The following is a description of a gene set: studied in species Homo sapiens Human Gene Set: MOOTHA_MITOCHONDRIA DNA microarrays can be used to identify gene expression changes characteristic of human disease. This is challenging, however, when relevant differences are subtle at the level of individual genes. We introduce an analytical strategy, Gene Set Enrichment Analysis, designed to detect modest but coordinate changes in the expression of groups of functionally related genes. Using this approach, we identify a set of genes involved in oxidative phosphorylation whose expression is coordinately decreased in human diabetic muscle. Expression of these genes is high at sites of insulin-mediated glucose disposal, activated by PGC-1alpha and correlated with total-body aerobic capacity. Our results associate this gene set with clinically important variation in human metabolism and illustrate the value of pathway relationships in the analysis of genomic profiling experiments. from publication Mootha VK, Lindgren CM, Eriksson KF, Subramanian A, Sihag S, Lehar J, Puigserver P, Carlsson E, Ridderstråle M, Laurila E, Houstis N, Daly MJ, Patterson N, Mesirov JP, Golub TR, Tamayo P, Spiegelman B, Lander ES, Hirschhorn JN, Altshuler D, Groop LC (PMID 12808457) Mitochondrial genes, and this is the list of marker genes: CLPX, UCP2, PDK1, COX6B1, ATPAF2, NPIPA1, MTIF2, TFB2M, MCAT, NDUFS6, R3HCC1L, STAR, IDH3B, NDUFS4, CROT, SLC25A31, LYPLA2, VDAC3, BEX3 (brain expressed X-linked 3), NDUFB8, SLC30A9, BIK, MRPL16 (mitochondrial ribosomal protein L16), MRPS18C, DLAT, TIMM22, GNAS, SLC25A15, HADHA, BID, DMAC2L, BCAT2, NME2, SLC25A20 (NCBI Gene Id 788), DGUOK, MRPL22, FXN, ANXA7, FAM3A, TXN2, AMACR, NDUFB2 (NCBI Gene Id 4708), HSPE1, TIMM17A, COX17, STARD3, PPOX, TOMM22, COX5A, SSBP1, SMCP, GPX4, PTPRA, SLC25A40, NDUFA6, POLR1B, ACP6, FIBP, ATP5MC2, TIMM44, CA5A, MRPL11 (NCBI Gene Id 65003), COX4I1, GFM1, CPS1, FHP2, DIABLO, POLRMT, SLC1A3, FDXR, MAP3K1, MRPS7, HADH, NDUFS1, CYP27A1, RPAIN, EHHADH, ATP5MG, COX6A1, ADCK2, SLC9A6, SHB, TBCB, PKLR, LGALS3, WARS2, ALDH2, ETFA, MTO1, BCL2A1, PCCA, YARS2, RAF1, AK4, FECH, MRPL19, TOMM40 (translocase of outer mitochondrial membrane 40), BDH1, PLA2G1B, CYP2E1, MPO, SHMT2, LCAT, CYB5A, ETFDH, HTRA2, MRPS14 (NCBI Gene Id 64961), MYCBP, AFG3L2, NDUFS5 (NADH:ubiquinone oxidoreductase subunit S5), ATP5PD, POR, MRPS18B, NDUFB4, ABCB7, PCK2, NDUFAB1, TPO, MRPL28, UQCRH, CASQ1 (NCBI Gene Id 844), TIMM8B, SLC25A28, MRPS11, ATP5F1E, PDHB, MMUT, ENDOG, CFAP410, BNIP3L, ACAA1, NDUFS2, HSPA9, SARDH, METTL17, TYMP, SPG7, HAX1, ME3, MRPS27, PPA1, MRPS22, POLG, CASP2, MRPL12 (mitochondrial ribosomal protein L12), COX10, SLC25A4, TOMM34, PRPF6, CYP11B1, NFS1, PDK3, COX7C, GATM, NDUFA10, SDHB, HADHB, SDHC, SLC25A10, MRPL18, SLC25A21 (solute carrier family 25 member 21), NDUFC1, SUCLG1, YME1L1, NDUFA7, SDHA, PSEN2, NDUFB1, CYB5R3, IMP3, COX7A2, ZNF33B, OTC, COX7B, CRY1, ACADVL, AMT, ACADL, PDK4, HMGCS2, TFB1M, SLC25A17, FDX1, ECHS1, UQCR11, TK2, UQCRFS1, PRKCD, MLYCD, UQCRB, MRPL46, ACAD8, NDUFC2, PYCR1, SLC25A32, G6PD, FARSA, COQ7, GAS8-AS1, CASP8, ATP5MF, ME2, NDUFB5, MRPL24, TWNK, EMC8, SLC25A12, MRPL42, NME4, MRPL9, PLA2G2A, ATP5IF1, DDX28, VAV1, APAF1, MRPL57, MTHFD2, MRPS15, SLC25A36, LONP1, NNT, SDHD (NCBI Gene Id 91899), TNFSF10, NDUFB6, PYGB, MTHFD1, SOD2, NDUFA3, BAK1, NCAPH2, ACADS, GLS2, APP, MBD3, GCK, MTRF1, PRDX3, SLC25A22, ACO2, ECI1, DUT, C1QBP, PC, TSFM, FH, NDUFB7, CPOX, CPT1B, SLC25A13, BCL2, CBARP (CACN subunit beta associated regulatory protein), LARS2 (leucyl-tRNA synthetase 2, mitochondrial), ERBB2, CKMT2, SLC25A38, UQCRC1, NPIPB3, UCP1, ABAT, ACADSB, CYBB, CLN3, POLR3B, DNASE2, POLG2, AK2, DHODH, MRPS12, BCS1L, TIMM8A, ATP5PF, CAD, DBT, OAZ3, MRPS31, H2BK1, SURF1, MRPL20, LMF2, COX6C, CS, MRPS28, TIMM10B, ABCF2, ETFB, MRPS35, PDHX, FARS2, TFAM, ATP5MJ, CYC1, CYP27B1, MRPL44, ACAA2, HSPD1, ATP5PB, CDC37P1, ECI2, GPD2, NDUFA5, BCKDK, COX6A2, SLC1A2, SLC25A5, CKMT1B, ALAS1, CYP11B2, BCKDHA, SLF2, NDUFA1, MRPS18A, MRPL13, DAP3, MTX1, GCDH, NDUFV2, MRPL17, NDUFB3, BAX, NBN, NDUFA8, PMPCB, SLC25A3, MTCH2, TIMM23, PAM16, HMGCL, MFN2, TAT, MTX2, MIPEP, CYCS, CDC42BPB, PDHA1, TIMM13, TOMM20, BCL2L1, MRPS30, IMMT, CRAT, NR3C1, COX11, GCFC2, AIFM1, ATP5ME, DECR1, UQCRC2, IVD, MRPS34, CYP11A1 (NCBI Gene Id 1583), TIMM9, AZIN1, FPGS, TP53, SIRT4, PCCB, ACADM, MB, VDAC2, MRPL33, MRPL49, COX15, ABCB8, CD40, CNOT7, TSPO (translocator protein), SLC25A23, MAST1, DLD, ATP5F1C, HCCS, TOMM70, GLUD1, ATP5F1D, CPT1A, HK1, GOT2, TIMM10, OXA1L (NCBI Gene Id 5018), DNM1L, ACAT1, MRPL2, SLC25A37, UCP3, RAN, CNNM4, MRPL48, GLYAT, TST, ATP5PO (ATP synthase peripheral stalk subunit OSCP), MAOB, SNCA, OAT, MRPL15 (mitochondrial ribosomal protein L15), SLC1A1, HTATSF1, ATP5F1B, SLC25A1, CYB5B, MRPS16, MRPL4, ARG2, MDH2, YWHAE, CYP20A1, NDUFA2, COX7A1, CYBA, DCTN6, GRB10, IDH3A, MRPS17, ATP5MC1, MRPS11P1, CA5B, NDUFS3 (NCBI Gene Id 4722), NT5M, SLC25A14, SBNO2, MTCH1, NDUFA4, MRPL34, MRPL39, MRPS33, MRPS10, IDH2, TIMM17B, ACOT9, COX8A, ATP5MC3, MPST, CAT, GATB, NDUFS8, MRPL35, MRPS2, GNLY, COX5B, ALDH4A1 (aldehyde dehydrogenase 4 family member A1), MRPL3, TUFM, SUPV3L1, TP53AIP1, MAOA, BCKDHB, CYP7A1, HPS1, TXNRD2, PIN4, SLC25A11, ACSL1